Given this list of marker genes LY75, XYLT2, PABPC4, OAS2, TRAF1, SORL1, NT5DC3, CLIP1, SH3BP5, MIF, PRKCQ, PTCD2, LPCAT1, CYP4V2, TFE3, AP1M2 (NCBI Gene Id 10053), PPA1, SLC26A6, LSM7, DOCK10, NT5C3A, DUSP2, INPP5B, UMPS, GATAD2A, HECA, CCT4, FBXL8, AP1G2, KICS2, SRGN, ICOSLG, H2AJ, NFE2L1, CRIM1, TMA16, EMILIN3, GRWD1, BHLHA15, PANX1, UNC5A, RBM43, AP1AR, PTK2B, ADAD2, GPR83, KIF12, FBXL6, ENO1, ENG, ALDH18A1, IKZF4 (NCBI Gene Id 64375, IKAROS family zinc finger 4), SOX5, AXL, THAP12, AFG3L2, UBQLNL, SLC26A11, MYO1G, LYVE1, TDRP, ZHX2, FOXP2, ODC1, SLC2A4RG, APEX1, PLEKHA2, RPL22L1, MSN, TRMT61A, RPS21, FLNB, SETD6, TRIM14, ZNF418, CD86, CRHR1, DENND1C, NAA25 (N-alpha-acetyltransferase 25, NatB auxiliary subunit), KCNG2, FAM174C, ACSL1, CA12, EEF1A2, TMEM106A, HIVEP3, SSH1, ARPC5L, ARMCX2, AGMAT, SPTBN1, RNF114, XXYLT1, HERC6, IKZF2, TGFBR3, RRP1B, POGLUT1, ADAR, CARNMT1, MRM1, BMP4, BHLHE40, PRMT2, SEC24A, KCNAB2, PHYHD1, RPL30, GID8, ZDHHC11, RGS10, GALNT12, ABHD11, SCAMP3, WARS1, AQR, DENND2D, IRF4, AATF, LAD1, TXNRD2, G6PC3, TMEM121B (transmembrane protein 121B), CAD, ITPK1, ZFP1, ELP3, RPL37, PDRG1, CPM, RECK, RTBDN, ING5, HECTD2, F2R, GALNT10, TDRD7, ATPSCKMT, AFG2A (AFG2 AAA ATPase homolog A), ARHGEF3, PARP3, MFNG, NR4A3, GRK6, ASPH, RRP7A, CEPT1, CRIP1, YAF2, EEF1D, UBXN11, ERAP1 (NCBI Gene Id 51752), TMCO4, NTRK2, NOTCH2, TSPYL2, GPR155, NEDD9, RARS1, GLUD1, SLC12A7, RTN4RL1, DNAH11, RPL35, HLA-DMA, SCLY, ANAPC11, RRP12, EHD3 (EH domain containing 3), MYH9, SH3BGRL3, TIMM8A, IFI27, GIMAP8, UNC13D, SEMA4F, PTPN18 (NCBI Gene Id 26469), STAT4, AGRN, TMEM165, RCC1L, WDR75, FRRS1, EIF5B, EFEMP2, ORAI3, ATM, ENOPH1, RP1, BATF, SELENOW, DAPL1, IRAK1, NSF, EMC2, HCN3, SNAPC1, WDR3, SRPK1, MRRF, here is a description of the gene set: Mouse thymocytes can be classified into four major subsets based on expression of CD4 and CD8 co-receptors. CD4-CD8- (double negative, DN) cells become CD4+CD8+ (double positive, DP) cells following productive T cell receptor (TCR) beta chain rearrangement. A small proportion of DP cells are selected through interaction of clonal TCRalpha/beta and MHC self peptide complex expressed on thymic stromal cells. DP cell expressing MHC class I-restricted TCR become CD4-CD8+ cells, which will finally differentiate into cytotoxic T cells, while MHC class II restricted selection generates CD4+CD8- helper lineage T cells. We used microarrays to identify genes important for thymocyte differentiation and lineage determination by profiling gene expression in different thymocyte subsets. from publication Egawa T, Littman DR (PMID 21873191) Genes down-regulated in comparison of CD4+ CD8+ thymocytes versus CD4- CD8+ thymocytes. Human Gene Set: GSE31082_DP_VS_CD8_SP_THYMOCYTE_DN studied in species Homo sapiens